The following is a description of a gene set: Human Gene Set: REACTOME_VLDL_CLEARANCE VLDL clearance studied in species Homo sapiens, and this is the list of marker genes: APOBR, APOC1, LSR, APOB, APOC4, VLDLR